The following is a description of a gene set: Genes containing one or more binding sites for (Carm1) in their promoter regions (TSS -1000,+100 bp) as identified by GTRD version 20.06 ChIP-seq harmonization. from publication Yevshin I, Sharipov R, Kolmykov S, Kondrakhin Y, Kolpakov F (PMID 30445619) Mouse Gene Set: CARM1_TARGET_GENES species: Mus musculus, and this is the list of marker genes: Or5ac15, Yars1, Phldb1, Arhgef4, Vmn1r-ps85 (NCBI Gene Id 384573), Tdrd6, Enoph1, Cntrl, Samd13, Kntc1, Blmh, Cuedc2, Aprt, S100pbp, Iscu, Nsd2, Ubxn4, Man2c1, Dcaf12, Sec11a, Pdzrn4, Rab18, Tmc6 (transmembrane channel-like gene family 6), Erc1, 1700039M10Rik, Wdr27, Zfp106, Adck2, Ptpa, Gamt, Gm12526, Gm12472, Eno1, Commd5, Map3k8, E330020D12Rik, Phb1, C630043F03Rik, Echs1, 0610038B21Rik, Ak1 (NCBI Gene Id 59018), Gm11960, Tns1, Trip10, Angel1, Gm15910, Rttn, Cep170 (NCBI Gene Id 98276), Sart3, 4933405L10Rik, Gm13094 (predicted gene 13094), Klk5, Myt1, Mir670hg (MIR670 host gene (non-protein coding)), 9430007M09Rik, A430102K17Rik, Dctn1, Mtdh, Aif1l, Tmc4, Gsdmc, Cox6a1, Rnf122, Ndufb5, Entpd6, Fam193a, 4833445I07Rik, Sez6l, Gm4744, Hdac9, Rsad2, Pipox, Gm807, Gm25630, Mir191, Rsrc2, Gm3764, Hnrnpdl, Mir425, Slc25a17 (solute carrier family 25 (mitochondrial carrier, peroxisomal membrane protein), member 17), Slc30a1, Sdccag8, Mir6359, Aspm, Tceanc, Btf3-ps8, Mt1, Arhgap10 (NCBI Gene Id 78514), Rbm25, Reln, Dab2ip, Erlin2, Usp53, Mgat1, 1700084J12Rik, Spmip7, 2900052L18Rik, Irf3, She, Col13a1, Tmem176b, Cyp19a1, Rmnd1, Fcmr, Nfatc2, Irag2, Eef1akmt1, Dnajc14 (DnaJ heat shock protein family (Hsp40) member C14), Csrnp3, Hes6, Mtss2, Mark2, Atp5mg, Zfp329, Gstt1, Atp6ap1l, Meig1 (NCBI Gene Id 17267), Kcnj16, Ctbp2, Arl8a, Gm11266, Adamts1, Mfng, Col16a1, Tle1, Mia2, Toe1, Peak1, Cdk4, Usp46, Zbtb3, Pold4, Nup42, Ndufaf3, Gm23889, Slc25a25, Tomm22, Tmem176a